The following is a description of a gene set: Splicing factor NOVA regulated synaptic proteins species: Homo sapiens Human Gene Set: WP_SPLICING_FACTOR_NOVA_REGULATED_SYNAPTIC_PROTEINS, and this is the list of marker genes: AGRN, MAPK4, CLSTN1, STX2, PRKCZ, CLASP1, GRIK2 (NCBI Gene Id 2898), KCNJ6, STXBP2, NTNG1, CSN3, CHL1, EFNA5, CAV2, RAP1GAP, MAP4, GRIN1, KCNQ2, EPB41L2, GABRG2, ANK3, GPHN, CADM1, NEO1, CADM3, GABBR2, NCDN, MAPK9, EPB41L1, CASK, APLP2, TERF2IP, DAB1, EPB41, CDH2, PLCB4, SNW1, ATP2B1, GRIN2B, KCNMA1, CAMK2G, EPB41L3